The following is a description of a gene set: Any process that stops, prevents, or reduces the frequency, rate, or extent of interleukin-4 production. species: Homo sapiens Human Gene Set: GOBP_NEGATIVE_REGULATION_OF_INTERLEUKIN_4_PRODUCTION, and this is the list of marker genes: LEF1, MIR320A, ZFPM1, FOXP3, NDFIP1, SCGB1A1, CD83, DDIT3